The following is a description of a gene set: Human Gene Set: HP_ABNORMAL_INTESTINE_MORPHOLOGY species: Homo sapiens An abnormality of the intestine. The closely related term enteropathy is used to refer to any disease of the intestine. Abnormal intestine morphology, and this is the list of marker genes: EDNRB, KLLN, UBE4B, PSTPIP1, MINPP1, HFE, BBS4, RPS28, HLA-DPA1, RAD51C, PTPN22, PGAP3, VARS1 (valyl-tRNA synthetase 1), KCNAB2, BAX, HCCS, PGAP2, UNC45A (unc-45 myosin chaperone A), PPP1R12A, ABCB1, ALG12, CEP41, NOTCH2, TCOF1, ACTA2, CCDC40, CALR, STX1A, APC, RPS29, CLIP2 (CAP-Gly domain containing linker protein 2), DNAI2, ATM (ATM serine/threonine kinase), EWSR1 (NCBI Gene Id 2130), CARD8, COMT, HEATR3, CENPF, SDHD, PACS1, FGF20, ERBB2, COG6, STAT1, SIX3, SETBP1, GMPPB, TSR2, TGFBR2, BBS9, IL6, RBM8A, RPL11, KAT6B, WAC, CAMK2A, SMC1A, VPS51, FANCA, ACADVL, ZFX, BUD23, COL3A1, TBL2, GUCY2C, INPP5E, NSUN2, TMEM231, EFEMP1, SDHB, HYDIN, BACH2, FLI1, ARPC5, MDM2, KIT, MYCN, ITGA6, PERCC1, KATNIP, PMS1, POLR1B, CTNNB1, LYN, RPL27, RPL31, ARX, STK11, CHEK2, DNAJB13, CFAP221, IFT74, ARL13B, RSPH9, IPO8, PIGW, SLC9A3, FERMT1, ODAD4, LIMK1, HLA-DPB1, SRCAP, GATA6, TCTN2, PLVAP, PIGY, COX7B, RPS7, XRCC2 (NCBI Gene Id 7516), ADAMTS3, BBS10, TNFRSF1A (TNF receptor superfamily member 1A), FANCI, TMEM218, CDKN2A, AHI1, AURKA, DLC1 (NCBI Gene Id 94517), SKI, ITGB2, ZFPM2, PMS2, MLH1, CCDC22, ARMC9, CDKN1A, SKIC2, PDGFRL, DDB1, BMPR1A, DNAJC30, PALB2, DCC, ZNF423, RPS24, NEK1, F5, RPL26, EXT2, COG8, SMAD7, TBC1D7, PIGV, FGFR3, IFT172, EXT1, DZIP1L, SEMA4A, NFKBIA, PDGFRB, PIK3CA, MAD1L1, EFEMP2, SDHA, FXN, DGAT1, SPAG1, MMEL1, DPYSL5, STX3, CEACAM3, GDNF, TRIP13, UNC13D, PKD1, CEP57, BUB1B, LRRC56, FLCN, CCBE1, ZMPSTE24, MT-ND4, CYBA, HLA-DQB1, TMEM237, ATRX, BBS12, MST1, B9D1, CDKN1B, KRAS, STAT3, ALG9, ROBO1, F13A1, FOXP3, RNF31, DNAAF6, SLC12A2, NCF4, UBR1, ERCC4, IL10RB, NUP88, PRKCZ, GP1BB, ADA2, TP63, DNAAF11, DNAH5, ATP7A, FLNB, NCF1, LEMD3, BCL10, TBK1, SGO1, DNAAF3, SERPINA1, GLI2, SLC6A8, F12, FOXH1 (forkhead box H1), AP1B1, B3GLCT, MSH6, SOX10, UBE2T, RPS10, TTC7A, CTLA4, CXCR4, GREM1, SCAPER, SIX1, POLR1D, GPC3, SPINK5, IKBKG, FOXE1, UFD1, TNFSF15, PMM2 (NCBI Gene Id 5373), MID1, SMO, CCNO, PORCN, HLA-B, ZIC3, CEP290, LZTFL1 (NCBI Gene Id 54585), BBIP1, RPL15, TBCE, DNAH11, MITF, CDK8, COL14A1, MTRFR, KIF7, PLA2G4A, ERCC2, NRTN, RPS15A, DNAL1, BBS2, ALDH18A1, PLA2G2A, LIG3, PKHD1, HLA-DQA1, RAD51, RPS17, SALL4, MYC (MYC proto-oncogene, bHLH transcription factor), PIGN, FANCD2, RPL35A, DDX3X, C1R, SAR1B, FANCC, SATB2, SLC6A14, SPEF2, GREB1L, RFC2, PIK3CD, CFC1, GPR35, DISP1, PTPRJ, CPLANE1, B2M, FREM1, OPLAH, MLH3 (mutL homolog 3), POLG, SMARCAL1, BBS5, MCM6, TTC8, MBD4, ELN, SDCCAG8, IGKC, KIFBP, RELA, GAS1, B9D2, KDM3B, CFTR, NPHP1, EDN3, CASP10, CCDC28B, PCSK1, PRTN3, DNAAF1, CEACAM6, SDHC, ODAD1, DLL1, NCF2, TAF6, MBTPS2, MIF, DIS3L2, CLMP, MT-TW, DACT1 (dishevelled binding antagonist of beta catenin 1), NAA10, RPS27, POLR1C, MYO1H, CFAP300, IGHG2, TMEM94, SEMA3C, AXIN2, RPL5, CDON, DYRK1A, IL2RA, TCTN1, RPGRIP1L, SPIB, FAH, FANCG, RPS26, HYLS1, ZIC2, CYBC1, DNAH9, BUB3, PRF1, WT1, SEMA3D, MT-TH, EYA1, ARL6, SRC, HDAC8, TYR, STAT5B (NCBI Gene Id 6777), MED12, SMAD2, WDPCP, CARD11, PRKAR1A, PHOX2B, MT-TS2, TCTN3, IL37, BBS1, FOCAD, SCLT1, FCHO1, LRBA, ODC1, JAK2, EIF4H, CHRM3, LTBP1, SYK, GNAS, ARL3, PTPN6, AIP, FOXF1, CHD8, DCTN4 (dynactin subunit 4), FLNA, KITLG, HNRNPK, MKKS, BRAF (NCBI Gene Id 673), GAS2L2, AMER1, RERE, PAX3, HEPACAM, MNX1, CASZ1, IRF1, ELANE, FGF8, RPL18, PIK3C2A, CFAP74, PPOX, GDF2, WNT4, SMAD4, CTBP1, ALG1, SEMA4D, MT-CO1, LONP1, VPS37D, ODAD3, NOTCH3, DOCK8, MLXIPL, PDGFRA, STK36, FKBP6, USF3 (upstream transcription factor family member 3), RSPH4A, HSPG2, TNPO3, IL21, CHST14, AAGAB (NCBI Gene Id 79719), TMEM67, DEF6 (NCBI Gene Id 50619), FCN3, PET117, WASHC5 (NCBI Gene Id 9897), TTC12, FRAS1, DNAI1, MSH2, KCNN4, PIGL, PDE11A, RIPK1, NODAL, RPS20, IL10RA, BUB1, LRP2, ZEB2, HIRA, GTF2IRD2, SLC11A1, RMRP, MMP21, MT-ND5, NSD1, BRIP1, FAS, DRC1, PDPN, DCLRE1B, RSPH3, STXBP2, BRD4, LMOD1, POLA1, FH, C1S, MT-TL1, PTPN12, HNRNPU, CAVIN1, SHH, DNAAF4, BBS7, PSMB10, NME5 (NME/NM23 family member 5), TOGARAM1, JAK1, WAS, FBLN5, EPCAM, MCIDAS, SKIC3, SEC23B, LIG4, CDKN2C, NLRC4, CEP104, IGHM, ABCD1, DHCR7, ECE1 (NCBI Gene Id 1889), APC2, TCF4, MSH3, FASLG, CRIPTO, PLG (plasminogen), WNT2B, CD3G, CCND1, NRAS, AP1S1, BRCA1, ERBB3, CBY1, KAT6A, MT-ND1, SREBF1, TBX1, GPR101, HMOX1, WNT9B, MIR17HG, DHODH, TEK, NEK10, TGFB1, KIF21A, PIGO, MTOR, DNAAF2, FANCE, OTUD5, KIF26A, SLC25A12, GTF2IRD1, SF3B4, XYLT2, WBP11, MASP2, LETM1, PI4KA, PALLD, IFT43, ADAM17, ITCH, JAK3, CEP19, MAP3K7, SALL1, MAGEL2, SHARPIN, DOK7, GPIHBP1, ALG6, BRCA2, SNAI2, HLA-DRB1, RPL9, DNAH1, NOP10, RPS6KA3, INAVA, MT-CO2, F13B, CEP120 (centrosomal protein 120), RFWD3, MEFV, BCOR (NCBI Gene Id 57686), ENG, MT-ND6, RAPSN, METTL27, MKS1, FBN2, NIPBL, BLNK, FGFR1, ARID1B, AIRE, GATA1, ASXL3 (ASXL transcriptional regulator 3), ISL1, NSD2 (nuclear receptor binding SET domain protein 2), SOCS1, RAD54B, DICER1, CHD7, IRF5, RSPH1 (radial spoke head component 1), CD55, CSPP1, PTCH1, KDM6A, ARVCF, POLD1, STX11, HPS1, COL5A1, KIAA0586, CARMIL2, WNT7B, DKC1, MYLK, NME8, ZMYND10, SIN3A, NPHP3 (NCBI Gene Id 27031), CTC1, AKT1, RPGR, CFAP298, SEC24C, GABRD, ACTG2, SLC37A4, MMP23B (matrix metallopeptidase 23B), KMT2D, COL1A1, PKP1, TLR2, RBCK1, RNU12, HMGA2, CCNQ, STAG2, ZPR1, ZNF699, OFD1, DSE, TMEM216, CFAP418, PTEN, L1CAM, TTR, LBX1 (ladybird homeobox 1), RNF43, ARPC1B, BAZ1B, FGFRL1, MYOD1, CPLX1, RPS19, MPI, RPL8, JMJD1C, TMEM270, DOCK11, GFRA1, DNAAF5, RAD21, COL5A2, LUZP1, ZMYM3, PIK3R1, POU2AF1, MT-TQ, SUFU, ASCL1, ITGB4, SH2B1, TMEM138, PDE6D, SPINT2, MEN1, LMNA, SMC3 (NCBI Gene Id 9126), DDX59, NDUFB11, SRP68, PIEZO1, GSTM3, IVNS1ABP, MAD2L2, DHCR24, SERPING1 (NCBI Gene Id 710), LTBP4, DYNC2H1, FARSB, BDNF, ALG8, MCC, GPC4 (NCBI Gene Id 2239), PIBF1, WIPF1, FAT4, ZAP70, MUTYH, MYH11, CIITA, UBE3B, TNFAIP3, SLC26A9, ELF4, FREM2, PLCG2, MYRF, VANGL1, PRMT7, RHBDF2, ASXL1, ITGA8, HMBS, CYBB, NTHL1, FANCB, TFAP2A (transcription factor AP-2 alpha), CLCA4, MT-TF, MYO5B, POLE, SLC18A3, RET, RTEL1, EP300 (NCBI Gene Id 2033), BLM, NOD2, ALG3, FCGR2A, CDKN2B, SPEN, CREBBP, RABL3, FOXJ1, IFT27, IL12A, PRDM16, INSR, CCDC39, TUBA1A, IRGM, SLX4, TYMP, SON, CC2D2A, FANCF, RARB, XIAP, KEAP1, ACVRL1, ABL1, GTF2I, TRIM32, LCT, DYM, CDC45, RECQL4, VPS35L, RBM10, FANCM, NF1, MVK, TWNK, IDS, MUSK, GCLC, SETD5, RAC2, DOCK2, TP53, MT-CO3, IL12RB1, GTF2H5, RRM2B, KIAA0753, HABP2, ODAD2 (outer dynein arm docking complex subunit 2), RFX6, FANCL, TOM1, PIK3CG, BICRA, TGIF1, STRA6, RTTN (NCBI Gene Id 284278), RPL35, EDNRA, CFAP45, RREB1, FGFR2